The following is a description of a gene set: Genes up-regulated in comparison of mast cells versus macrophages. from publication Jeffrey KL, Brummer T, Rolph MS, Liu SM, Callejas NA, Grumont RJ, Gillieron C, Mackay F, Grey S, Camps M, Rommel C, Gerondakis SD, Mackay CR (PMID 16474395) Human Gene Set: GSE3982_MAST_CELL_VS_MAC_UP studied in species Homo sapiens In the present study we used Affymetrix oligonucleotide microarrays to produce gene transcription profiles for the major leukocyte types in humans. This comprehensive dataset enabled us to not only establish which genes were expressed in each leukocyte type, but also which genes were expressed in each subset after activation. The used of a comprehensive dataset of gene profiles from all the major human leukocyte subsets enabled a novel and powerful means for identification of genes associated with single leukocyte subsets, or different immune paradigms., and this is the list of marker genes: ZCCHC24, GDF3, CCNA1, PURA, ITK, PDE4D, SLC10A3, SF3B5, WDR74, CDC23, TMEM14A, IDO1, SLF2, ETV5, ZMYND8, SNW1, GUCY1A2, ALDH18A1, ZNF137P, HNRNPDL, ESYT1, RPL21, KHDRBS2, TAF1D, ZBTB33, ATXN7L3B, CLK1, NPRL2 (NCBI Gene Id 10641), ELK4, REG1CP, POLA1, CUTA, CNN2, SET, MINPP1, SLC2A11, SEMA4C (semaphorin 4C), TP53, UTP20, BRF2, MED20, PPP3R1, CASP6, FBXO11 (F-box protein 11), WDR82, CTBP1, CHN2, PRKACA, ZFAND1, HAUS5, BMP2K, NCBP3, FLOT1, TEX10, DUSP10, EIF2AK1, MRFAP1L1 (NCBI Gene Id 114932), ACTB, NLE1, RHOBTB3, SLK, ECHDC2, RGS10, FBN1, ARL4C (ADP ribosylation factor like GTPase 4C), SRPK1, EXOSC1, PCID2, CTCF, LYL1, IFRD1, ZFTA, APEX1, DUSP12, MIS12, RSL24D1, LUC7L2, JAK1, SP3, CDK4, URB1, PGBD5, RO60, PLA2G4A, ACSM3, STAT5B, DNAH17, N6AMT1, PRKDC, STK32B, FAM216A, ATP8B4 (NCBI Gene Id 79895), GAR1, CACNA2D2, RPS4X, TMX4, SORBS1, ADI1, IGF2BP3, CAVIN2, RANBP1, ITM2C, GMPR, ASS1, ONECUT1, RBM26, SLFN12, GOLGA8B, ARHGAP25, CYFIP2, TMEM74B, LIPT1, CD38, WDR33, RCL1, HSD17B10, WDR70, DESI2, DOCK9 (NCBI Gene Id 23348), ATP5IF1, TUG1, DNMBP, HMG20A, FOXJ3, CD226, MYH7B, TSPYL4, ZKSCAN4, RBM10, DXO, RNPS1 (RNA binding protein with serine rich domain 1), LPAL2, ZNF10, METTL18, MLC1, ABHD6, MKRN1, GPX7, RPL26, SRPRB, GSTA4, PCMT1, CTR9, ZFYVE9, RPL11, HSPA2, RPS3 (ribosomal protein S3), MUC2, TRA2A, GFOD2, RNF8, RTN3, MUTYH, TSPYL1, SMYD3, P2RY10, ZNF510 (NCBI Gene Id 22869), SRSF5, SEMA3E, ZNF155, TMOD1, TLE3, MAEA, MTG1, FBXW4, PEX11B, HMGN1, HSF2, BRD8, ATP8A2, IFITM1, ZXDC, TTC19, ZNF529, LRRC20, MAST4, STK26, TFAM (NCBI Gene Id 8033), NCR3, KIF21B, RERE, TAOK3, NTRK1, TFDP2, SKIC8, LGALS8, STAG2, ADAMTS3, PPP1R3D, HERC1, CCNT2, DCUN1D4, RPL35A, GPR6, TRPM8, PHIP, PUM2, FAM30A, RPL36